Given this list of marker genes ADD3, VPS35L, OR3A2, USP6, RASAL2, N4BP2L1, NACA, BTN2A1, CPN1, SORCS3, KIF5C, LY75, MBP, DCLK1, IRAK4, C1orf115, RAF1, CYB561, OSBP, PRKY, IL11RA, USP36, COLEC11, CSAD, ZBTB25, KBTBD2, PEX5L, MACF1, AKAP9, PTX3, UGT8, ZNF337, IRF7, MCMBP, SDK2 (NCBI Gene Id 54549), CHMP7, CRYL1, CAST, ANXA1, GIMAP5, KLRF1, MMP24 (matrix metallopeptidase 24), NLRP1, CPB1, DKFZP434A062, CD44, H2AP, MUC2, NOSIP, SRPX2, DAZAP2, TEX28 (NCBI Gene Id 1527), WAS, KIF17, ZZEF1, SMURF1, MTARC2, MAGEA4, TMEM63A, WDR33, PLCB1 (phospholipase C beta 1), SESN1, HERC1, RIN1, SLCO1B3, PKD1P1, AHCYL2, PDE4B, PKP3, ZFP36L2, MAD1L1, EIF3G, CLCA4, OFD1, WNT7A, RMDN3, ZNF506, GSR, DFFB, S100A13, RHBDL1, BTG1, DIDO1, ZBTB44, ITGB2, NPR2, SLC46A3, INAVA, BRWD1, GDAP1L1, GCNT3, HLA-B, TRBC1 (NCBI Gene Id 28639), EPCAM, TXK, GASK1B, BBOF1, FKBP9, MKRN1, EIF1 (eukaryotic translation initiation factor 1), RBL2, OBI1, TSC22D1 (TSC22 domain family member 1), GLRA2, FRAT1, CYB5R1, JRK, VAV3, IDO1, TULP4, WWP1, CELSR1, PI4KA, SELL, IRF9, ZNF184, HLA-DPB1, BIN1, ELAVL4, CCDC170, LMBR1L, ESR1, PCDHB13, PAPOLG, MYH3 (NCBI Gene Id 4621), RERGL, CTSO, EZH1, SRSF5, ECHDC2, C1orf54 (NCBI Gene Id 79630), WDR59, PLXDC1, STAT4, MALT1, CLOCK, PCOLCE2, ZBED5, VPS13D, HSF2, LONP2, EGFR (NCBI Gene Id 1956), BID, CTSF, FXYD3, GPBP1L1 (NCBI Gene Id 60313), HOXB8, LGALS3BP, MSL2, SOD3, RPL23AP32, ITK, MTRF1L, MID2, TUBG2, RAB40C, GPRASP1, GALR3, DZANK1, IFI44L, CCDC102B, ZDHHC7, CD96, CHCHD7, PNRC1, FMO3, LARS1, EPHX2, PUM1, CALM1, ZNF142, TRANK1, CD300A, HBP1, KAT6B, DPEP2, UTS2, CARS2, TRIM22, RXRA, NPVF, RPS27 (ribosomal protein S27), SLC14A1, IL6ST, JMJD1C, STX7, ZNF136, ALPK1, GFRA2, EXT2, TMEM43, DUSP1, ARHGAP15 (NCBI Gene Id 55843), MEGF9, ARHGEF3 (Rho guanine nucleotide exchange factor 3), ECE1, VPS9D1, HNRNPA3, here is a description of the gene set: species: Homo sapiens Human Gene Set: GSE3982_CENT_MEMORY_CD4_TCELL_VS_TH2_UP Genes up-regulated in comparison of central memory CD4 T cells versus Th2 cells. from publication Jeffrey KL, Brummer T, Rolph MS, Liu SM, Callejas NA, Grumont RJ, Gillieron C, Mackay F, Grey S, Camps M, Rommel C, Gerondakis SD, Mackay CR (PMID 16474395) In the present study we used Affymetrix oligonucleotide microarrays to produce gene transcription profiles for the major leukocyte types in humans. This comprehensive dataset enabled us to not only establish which genes were expressed in each leukocyte type, but also which genes were expressed in each subset after activation. The used of a comprehensive dataset of gene profiles from all the major human leukocyte subsets enabled a novel and powerful means for identification of genes associated with single leukocyte subsets, or different immune paradigms.